The following is a description of a gene set: Chemotherapy, radiation, and growth inhibitory drugs preferentially eliminate actively growing cancer cells. Cancer recurrence is currently thought to be due to nondividing cancer stem/progenitor cells that are resistant to these therapies. Different therapeutic approaches need to be considered for the elimination of the cancer stem cell population. Immunotherapy is one such approach. In addition to specificity and lack of toxicity, immunotherapy targets cancer cells irrespective of their state of proliferation, as long as they express particular tumor antigens. For that reason, it is important to examine if the tumor antigens that are currently being tested as immunotherapeutic agents are also present on cancer stem cells. This study aimed to determine if one well-known tumor antigen, MUC1, which is being tested as an immunotherapy target on tumor cells, is also expressed on the quiescent cancer stem/progenitor cells. We used the so-called side population (SP) cells found in the MCF7 breast cancer cell line, which we first confirmed by cell surface markers and gene profiling to be highly enriched in cells that fulfill specific functional, phenotypic, and molecular criteria for being tumor stem/progenitor cells. We show that these cells express MUC1 and give rise to MUC1(+) tumors in vivo, which maintain the MUC1(+) SP population. MUC1 on SP cells is hypoglycosylated and heavily sialylated; the characteristics of the tumor-specific form were expressed on mature cancer cells and recognized by tumor-specific T cells and antibodies. This suggests that stem/progenitor cells, like mature tumor cells, would be targets of MUC1-directed immunotherapy. Down-regulated genes in the cancer progenitor (stem) cells corresponding to side population (SP) MCF7 cells (breast cancer) positive for MUC1. from publication Engelmann K, Shen H, Finn OJ (PMID 18381450) species: Homo sapiens Human Gene Set: ENGELMANN_CANCER_PROGENITORS_DN, and this is the list of marker genes: CEACAM6, RBM4B, IL4R, EVL, VPS37D, BNIPL, LRRFIP2, OSGIN1 (oxidative stress induced growth inhibitor 1), CITED4 (NCBI Gene Id 163732), KRT13, GALNT4, REC8, LRCH4, AKR1C1, CD44, BMP4, CALML5 (NCBI Gene Id 51806), TXNIP, CLIC3, TRPV4, OXTR, EEIG1, SYBU, RASAL1, AGR3, S100P, GADD45B, MAFB, SYTL4, ID1, CCN2, NBL1, NPIPA1, RLN2, HS3ST3A1, PCP4, GSN, PTGFRN, SCUBE2, CEBPA, IGSF1, GP1BB, PNKD, HSPA2, AKR1C3, ADCY1, KLK6, ST6GALNAC2, ANXA8L1, FGFR3, BMP7, SLX1B, FBXO27 (NCBI Gene Id 126433), FN1, SGK1, TLCD3B, SFXN2, AKR1C2, UGDH, SEPTIN5, DVL3, BMP5, CAPS, SLC35C1, ZNF296, RAPGEFL1, CORO2A, ABCC3, TFF3